Given this list of marker genes TM7SF2, GRK3-AS1, ARHGEF16, CDKN1C, TMEM120A, ETFA, SPTB, ALDH1L1-AS2, TENM3-AS1 (TENM3 antisense RNA 1), LPL (lipoprotein lipase), SLC2A4, CPNE4, ECHDC3, STRADB, LINC02082, ALDH1L1, ALK, CYP4F32P, COQ8A, PPP1R14A, ST3GAL6, HADH (NCBI Gene Id 3033), LINC01586, SLC4A4, MCCC1, POLN, TRIM55, BNIP3, LINC01612, L2HGDH, DCXR, FAM89A, STBD1, BNIP3L, IZUMO4, STOX1, UQCRH, ELOVL3, TWIST1, MRPL15P1, GDF5, MTARC2, ACSS2, SUCLG1, CDKN2C, RIDA, RNF32-DT, PVALEF, GPT, ALDH6A1, ACADM, MESP1, C14orf180, FRMD1, GLUL, TBX4, ACSS3, THYN1, CKB, LDHD, MTARC1, COX7C, ALPK3, SLC7A10, BCKDHB, PDK2, RHOT1, FAM222A-AS1, SLC25A1, REEP2, NAALAD2 (NCBI Gene Id 10003), ORMDL3, COQ9, PYGM, NIPSNAP3B, AKT2, UQCRC2, TTC38, PMM1, GCDH, ATP6V0E2-AS1, DEFB132, APOB, AUH, GPT2, NAT8L, TTC36, DAPK2, ACVR1C, CYB5A, ACAT1, ESR2, AZGP1, KGD4, NDUFB5, PCYT2, FAT3, ANKRD20A8P, SERTAD4BP, GJC3, FAAH, TTC39A, ASPG, FBXO27, PPP1R16A, LACTB2, SLC25A23, GYS1, FASN, EMC3, here is a description of the gene set: Human Gene Set: KONIGORSKI_INCREASED_SUBCUTANEOUS_ADIPOSE_TISSUE_TOTAL_RATIO_UP Genes that exhibit a positive CJAMP (Copula-based joint analysis of multiple phenotypes) beta estimate (beta > 0) for association with subcutaneous-to-total adipose tissue ratio. from publication Konigorski S, Janke J, Patone G, Bergmann MM, Lippert C, Hübner N, Kaaks R, Boeing H, Pischon T (PMID 35953519) species: Homo sapiens Many studies have shown that abdominal adiposity is more strongly related to health risks than peripheral adiposity. However, the underlying pathways are still poorly understood. In this cross-sectional study using data from RNA-sequencing experiments and whole-body MRI scans of 200 participants in the EPIC-Potsdam cohort, our aim was to identify novel genes whose gene expression in subcutaneous adipose tissue has an effect on body fat mass (BFM) and body fat distribution (BFD). The analysis identified genes associated with adiposity, of which 531 encode a known protein and 487 are novel candidate genes for obesity. Enrichment analyses indicated that BFM-associated genes were characterized by their higher than expected involvement in cellular, regulatory and immune system processes, and BFD-associated genes by their involvement in cellular, metabolic, and regulatory processes. Mendelian Randomization analyses suggested that the gene expression of genes was causally related to BFM and BFD. Six genes were replicated in UK Biobank.